Given this list of marker genes CAMK1, IDI2-AS1, TEDC2, KIF11, ZNF90, WDHD1, GINS4, TROAP, XRCC2, LMNB1, EXO1, DDX11, SGO1, MYBL2, CCNB2, AURKA, CCNA2, KANK2, PHGDH, TUBAL3, ANLN, TOP2A, MCM2, MTFR2, PLK4, NCAPG2, E2F8, FEN1, CES3 (NCBI Gene Id 79984), DEPDC1B, CIT, FOXM1, PRR15L, UCN2, TK1, ZSCAN31, TRIM45, RFXAP, JRK, PGPEP1, RBL1, CLSPN, PIK3C2B, RRM2, SFXN2, ORC1, SLC46A1, CDCA3, CDCA5, ZNF324B, NCAPH, RBBP8NL, MEX3A, ZWINT, TFAP4, MND1 (NCBI Gene Id 84057), CENPE, WDR76, MIR503HG, SHCBP1, MFSD13A, PLK1, IRAG2, TCF19, MCM7, ZNF331, FADS1, ZNF714, TRAIP, LURAP1L, OSBPL7, PPARGC1B, SKA1, CENPO, KIF20A, KIF15, BUB1B, PRR11 (NCBI Gene Id 55771), FANCG (FA complementation group G), FANCB, FANCI, UBE2C, DIAPH3, PRIM1, TACC3, SPC25, NUF2, PTTG1, ERCC6L, SPAG5, DTL, SUV39H1, OIP5, KIF24, PSRC1, KIF2C, HMMR, SLITRK6, BLM, GOLGA2P5, TMCC2, UBE2T, CCDC34, FAM111B, LUARIS, NUSAP1, BRCA1, CHTF18, CDC25C, E2F1, LINC00847, DDX12P, PIMREG, CDCA8 (NCBI Gene Id 55143), MSTO2P, PCLAF, ASF1B, CASTOR1, CDC25A, CDC7, FAM161A, CEBPA-DT, PRC1, MAP3K12, KIF18B, HILPDA, ZNF608, MIPEPP3, ZNF248, NCAPG, PER2, ATAD5, NSD2, THBD, RHNO1, HROB, HJURP, CEP55, CCDC18, TEF, HASPIN, KNL1, MCM10, SNHG4, TTK, RARB, CDCA7, UHRF1, ZNF782, BAIAP2-DT, KIFC1, WDR62, ZNF395, S1PR5, AURKB, FOXA2, GCNT3, PADI1, NEK2, ARPIN, NEIL3, UPK3B, EME1, PKMYT1, KIF14, MCM4, PADI3, CENPI, CDKN3, VAV3, CDC45, EPN3, BIRC5, CENPM, CBX2, CDCA2, CDC6, RAD54L, SKA3, GPATCH11, DHFR, RAD51, CDT1, NEXN, KIF4A (kinesin family member 4A), CENPF, GINS2, here is a description of the gene set: Analysis of the transcriptional response to SARS-CoV-2 compared with other respiratory viruses, including MERS-CoV, SARS-CoV-1 (SARS), human parainfluenza virus 3 (HPIV3), respiratory syncytial virus (RSV), and IAV. Human Gene Set: BLANCO_MELO_BRONCHIAL_EPITHELIAL_CELLS_INFLUENZA_A_DEL_NS1_INFECTION_DN Genes down-regulated on infection of normal human bronchial epithelial cells by mutant Influenza A lacking its antiviral antagonist (IAV_NS1) (MOI: 3, 12hpi) species: Homo sapiens from publication Blanco-Melo D, Nilsson-Payant BE, Liu WC, Uhl S, Hoagland D, Møller R, Jordan TX, Oishi K, Panis M, Sachs D, Wang TT, Schwartz RE, Lim JK, Albrecht RA, tenOever BR (PMID 32416070)